Given this list of marker genes Cck, Runx1, Ccdc65, Zfp819, Arid3a, Klhl18, Herpud2, Adam22, Pank3, Sptssb, Dio2, Igf1, Disp3, Itih1, Tmx3, Arid5b, Chchd3, Smim10l1, Ctif, Brd9, Trim52, Tmem35a, Man2a1, Zbtb10, Npas2, Grm4, Efcab11, Smpd1, Amy2a4, Emb, Rce1, Sox6, Lifr, Wscd2, Sgms1, Slc38a9, Prpf3, Lmo3, Gigyf1, Gtf2f2, Npat, Nufip1, Ctdspl2, Sp1, Crppa, Smad6, Fgf20, Mtmr7 (myotubularin related protein 7), Ktn1, Soat1, Fbxl15, Zfand5, Raly, Cd28, Atf2, Unc5d, Ptprv, Lpgat1, Fgfr3, Cpeb3, Rbfox2, Scrib, Tnfsf12, Ptgfrn, Lamp3, Ints2, Osgin2 (NCBI Gene Id 209212), Cyp2j5, Slc25a16, Tacr2, Secisbp2, Zfp354b, Cdh12, Magi1, Caskin1, Acot8, Zfp710, Nfx1, Ppp4r3a, Spata31f1a, Ino80, Sec61a2, Nptx1, Bnc2, Fign, Tut4, Ostf1, Eif5, Cpne2, Fbxo11, Xrra1, Hycc2, Bicd1, Apol6, Sephs2, Sp3, Tmcc3, Trio, Asic1, Mafg, Cask, 4930432M17Rik, Jrkl, Adam10, Tent5a, Trim8, Gorasp2, 2810408A11Rik (RIKEN cDNA 2810408A11 gene), Pter, Apbb2, Zbtb41, Atxn7l1, Bhlhb9, Zfhx3, Atmin, Kif21a, Abhd10, Kif12, Patl1, Kat6a, Mark2, Fignl1, Sf1, Tmem17, Zfp101 (zinc finger protein 101), Msl1, Ppp2cb, Plpp3, Ms4a4c, Cacna1d, Sphk1, Slain2, Hoxd8, Mpp7, Mtmr1, Abhd13, Ptch2, Des, Gpr158, Pappa2, Tfap2b, Ttc23, Dsg1a, Rpn2, Cd53 (NCBI Gene Id 99593), Plppr4, Tbc1d8b, Stxbp5l, Cd2ap, Polr3e, Calcr, Gm14325, Vegfa, Chrdl1, Timd2, Mustn1 (musculoskeletal, embryonic nuclear protein 1), Amy2a2, Caps2, Irs1, Ms4a4b, Ppil3, Papolg, Gad1, Arhgap17, Jtb, Dclk3, Spred1, Iqub, Zfp397, Hmx2, Lbh, Gtf3c4, Fgf21, Slc40a1, Tmem260, Ptpn21, Pnrc2, Gtf2ird2, Cadm2 (NCBI Gene Id 72986), Cdh1, Vps4a (NCBI Gene Id 78220), Elavl4, Prkca (NCBI Gene Id 18750), Hhip, Tekt3, Ano4, Cab39l, Osbpl3, Pcdh20, Lpin2, Dlgap1, Spata31f1b, Plp1, Cnr1 (cannabinoid receptor 1), Amy2a3, Sh2d4a, Klhl11, Galnt2, Pou2f1, Atxn3, Wbp2, Mroh9, Leng8, Itga2b, Fam199x (family with sequence similarity 199, X-linked), Pdgfra, Wnt7a, Gria3, Wbp1, Saxo2, Sowaha, Ptbp1, Il23a, Pnp, Zbtb47, Zfp971, Satb1, Cpeb2, Cimip2a, Bcl11a, Foxk1, Nav2 (NCBI Gene Id 78286), 1110004F10Rik, Rora, Rsbn1, Extl3, Stk26, Cpox, Nppc, Bdh1, B3gnt5, Lrrtm4, Wnt3, Cnot9, Ddost, Svs4, Fam169a, Mesp2, Fgf12, Tgfbr3, Tgfa, Iqgap2, Zrsr2 (zinc finger (CCCH type), RNA binding motif and serine/arginine rich 2), Ubr5, Synj2bp, Acox1, Il6st, Hapln1, Pds5b, Runx2, Kdm4b, St18, Foxn2, Adamtsl1, Dlst, Ppip5k2, Rbpms2, Psmd10, Nherf1, Ccdc106, Rbm20, Supt5, Cyp2c50, Rmi1 (NCBI Gene Id 97878), Stx11, Dhrs11, Pcdhb7, Tmem248, Nptx2, Ptpre, Spata19, Gng2, Ifnlr1, Nxnl1, Cul4b, Ro60, Setx, Klhdc10 (NCBI Gene Id 76788), Rsf1, Rbbp6, Dclk1, Zfx, Atp6v1c1 (NCBI Gene Id 98003), Celf3, Rgl1, Nemp1, Nek4, here is a description of the gene set: from publication Chen Y, Wang X (PMID 31504780) Mouse Gene Set: MIR_7215_5P Genes predicted to be targets of miRBase v22 microRNA mmu_miR_7215_5p in miRDB v6.0 with MirTarget v4 prediction scores > 80 (high confidence targets). studied in species Mus musculus